The following is a description of a gene set: studied in species Homo sapiens Inwardly rectifying K+ channels Human Gene Set: REACTOME_INWARDLY_RECTIFYING_K_CHANNELS, and this is the list of marker genes: GNG13, KCNJ11, GNG11, GNG5, KCNJ5, GNB5, KCNJ3 (potassium inwardly rectifying channel subfamily J member 3), GNB3, GNGT1, GNGT2, KCNJ16, KCNJ2, GNG7, KCNJ10, GNB2, KCNJ8, GNG2, KCNJ6, GNB4, KCNJ1, KCNJ9, ABCC8, GNG4, GNG3, GNG12, KCNJ12 (NCBI Gene Id 92081), GNG10, ABCC9, KCNJ15, KCNJ14, GNG8, GNB1, GABBR1, GABBR2, KCNJ4 (potassium inwardly rectifying channel subfamily J member 4)